Given this list of marker genes Stxbp5, Slc18a2, Cadps, Syt4, Syt5, Kif1a, here is a description of the gene set: studied in species Mus musculus The lipid bilayer surrounding a neuronal dense core vesicle. Mouse Gene Set: GOCC_NEURONAL_DENSE_CORE_VESICLE_MEMBRANE